The following is a description of a gene set: species: Mus musculus Any process that activates or increases the frequency, rate or extent of cellular respiration. Mouse Gene Set: GOBP_POSITIVE_REGULATION_OF_CELLULAR_RESPIRATION, and this is the list of marker genes: Oas1g, Oas1c, Chchd4, Oas1a, Ifnar1, Opn3, Ifnlr1, Oas1d, Vcp, Iscu, Oas1b, Myog, Nupr1, Oas1h, Oas1f, Prelid1, Oas1e, Il10rb, Park7, Myc, Il4, Pink1, Mfn2, Ifng